The following is a description of a gene set: studied in species Homo sapiens Human Gene Set: GOBP_ORGANELLE_DISASSEMBLY The disaggregation of an organelle into its constituent components., and this is the list of marker genes: MAP4, USP10, GOLGA2, ABCE1, KLHDC10, PLAAT3, ELAC1, VCP, FAF2, KIF5B, LTN1, PLIN2, RRP7A, MTIF3, SAYSD1, EIF2D, VRK1, MRPL58, STX5, NEDD9, MTRFR, MRRF, UFSP2, ASCC2, KLC1, MCTS1, AURKA, DYRK3, PLAAT1, TRIP4, SPAST, GBF1, MTIF2 (mitochondrial translational initiation factor 2), PRKAA2, TCF25, KIF9, TRIM21, DENR, RNF14, DDRGK1, GTPBP2, PTRH1, HDAC6, RCHY1, PLK3, HBS1L, ZFAND1, PRKAA1, ZNF598, KIF19, CDK5RAP3, SKIC3, ANKZF1, SKIC8, PELO, RNF25, GCN1, NEMF, PLIN3, UFL1, PNPLA2, MTRES1, CHKA, SKIC2, GIGYF2, KAT5, RACK1, AFG2B, EIF4E2, ASCC3, TRNT1, CDK1, GFM2